Given this list of marker genes KCND2, NEFL, CD19, PRSS12, CNRIP1, NELL2, NDRG4, MYCL, GPR27, CDK5R1, FAM13C, INKA2, HPCAL4, RHOBTB3, here is a description of the gene set: from publication Kim YH, Girard L, Giacomini CP, Wang P, Hernandez-Boussard T, Tibshirani R, Minna JD, Pollack JR (PMID 16116477) studied in species Homo sapiens Genes positively correlated with amplifications of MYCL1 in SCLC (small cell lung cancer) cell lines. DNA amplifications and deletions frequently contribute to the development and progression of lung cancer. To identify such novel alterations in small cell lung cancer (SCLC), we performed comparative genomic hybridization on a set of 24 SCLC cell lines, using cDNA microarrays representing approximately 22,000 human genes (providing an average mapping resolution of <70 kb). We identified localized DNA amplifications corresponding to oncogenes known to be amplified in SCLC, including MYC (8q24), MYCN (2p24) and MYCL1 (1p34). Additional highly localized DNA amplifications suggested candidate oncogenes not previously identified as amplified in SCLC, including the antiapoptotic genes TNFRSF4 (1p36), DAD1 (14q11), BCL2L1 (20q11) and BCL2L2 (14q11). Likewise, newly discovered PCR-validated homozygous deletions suggested candidate tumor-suppressor genes, including the proapoptotic genes MAPK10 (4q21) and TNFRSF6 (10q23). To characterize the effect of DNA amplification on gene expression patterns, we performed expression profiling using the same microarray platform. Among our findings, we identified sets of genes whose expression correlated with MYC, MYCN or MYCL1 amplification, with surprisingly little overlap among gene sets. While both MYC and MYCN amplification were associated with increased and decreased expression of known MYC upregulated and downregulated targets, respectively, MYCL1 amplification was associated only with the latter. Our findings support a role of altered apoptotic balance in the pathogenesis of SCLC, and suggest that MYC family genes might affect oncogenesis through distinct sets of targets, in particular implicating the importance of transcriptional repression. Human Gene Set: KIM_MYCL1_AMPLIFICATION_TARGETS_UP